Given this list of marker genes KRT18P10, TMEM235, AGMO, APOD, LINC03048, MYRF, BMP8B, COL20A1, NBEAP2, GJB1, DCAF4L2, NT5E (5'-nucleotidase ecto), LINC01561, NR0B1, MOG, ERBB3 (NCBI Gene Id 619500), H1-9P (NCBI Gene Id 373861), KLRC4, ASIC4-AS1, ZNF365, MIR219A2HG, OLIG1, OLIG2, LINC01254, KLRK1, CHRM3-AS2, SSTR1, LINC02199, SCRG1, CLDN11, UGT8, TNR-IT1, RNU6-994P, LINC02283, TENT5B, BCAS1, PLAAT1, ENSG00000228174, GDNF, MOBP, PCDH15, RN7SL795P, FCRLA, KLRC3, ENSG00000234173, TMEM212, NKX2-2, DMRT2, RNU6-564P, LHFPL3, MMP16, GPR17, TNR, KLRK1-AS1, GDF6, CHAD, GDNF-AS1, KLRC4-KLRK1, ENPP6, PLPP4, MATN1, NOVA1-DT (NCBI Gene Id 387977), VSX1, MYT1 (NCBI Gene Id 4661), LINC02895, MAG, CHRM3, SOX10, KLRC2, HMX1 (NCBI Gene Id 3166), ASIC4, ENSG00000236494, LINC01170 (long intergenic non-protein coding RNA 1170), ATP13A5-AS1, PDGFRA, FA2H, RNU6-687P, LINC00237, GAL3ST1, here is a description of the gene set: Marker genes curated from the annotated cluster as represented in the Descartes Human Gene Expression During Development database. The gene expression program underlying the specification of human cell types is of fundamental interest. The study authors generated human cell atlases of gene expression and chromatin accessibility in fetal tissues. For gene expression, the study authors applied three-level combinatorial indexing to >110 samples representing 15 organs, ultimately profiling ~4 million single cells. The study authors leveraged the literature and other atlases to identify and annotate hundreds of cell types and subtypes, both within and across tissues. Our analyses focused on organ-specific specializations of broadly distributed cell types (such as blood, endothelial, and epithelial), sites of fetal erythropoiesis (which notably included the adrenal gland), and integration with mouse developmental atlases (such as conserved specification of blood cells). These data represent a rich resource for the exploration of in vivo human gene expression in diverse tissues and cell types. from publication Cao J, O'Day DR, Pliner HA, Kingsley PD, Deng M, Daza RM, Zager MA, Aldinger KA, Blecher-Gonen R, Zhang F, Spielmann M, Palis J, Doherty D, Steemers FJ, Glass IA, Trapnell C, Shendure J (PMID 33184181) species: Homo sapiens Human Gene Set: DESCARTES_FETAL_CEREBRUM_OLIGODENDROCYTES